The following is a description of a gene set: species: Mus musculus Mouse Gene Set: WP_FIBRIN_COMPLEMENT_RECEPTOR_3_SIGNALING_PATHWAY Fibrin complement receptor 3 signaling pathway, and this is the list of marker genes: Ticam2, Cblb, Ifnb1, Nfkb1, Rel, Il12b, Itgb2, Src, Akt1, Syk, Chuk, Tirap, Fgg, Tlr4, Irf3, Fcer1g, Itgam, Fga, Ticam1, Plg, Tyrobp, Myd88, Nos2, Traf6, Rhoa, Plat, Cxcl10, Irak2, Pik3ca, Ccl2, Rassf5, Cxcl3, Ly96, Irak4, Rela, Fgb, Ikbkg, Tnf, Cd14, Il6, Irak1, Tlr3, Ikbkb, Lbp